The following is a description of a gene set: species: Homo sapiens Genes having at least one occurrence of the motif DNNGGRGGGWWNNNN in the regions spanning 4 kb centered on their transcription starting sites. This matches the SPZ1 transcription factor binding site V$SPZ1_01 (v7.4 TRANSFAC). Human Gene Set: SPZ1_01, and this is the list of marker genes: EIF4G2, ABHD8, CRMP1, BCL7A, EIF4G1, PITPNC1, YTHDF2, LCOR, KCNC1, EIF4E, TOM1L2 (NCBI Gene Id 246315), CTCF, HR, TRMT2A, RIMS1, ADAMTS9, USPL1, TIAM1, MRPL40, CPNE1, GTF2A1, STK35, EPN3, PTMS, DLG2, POU3F3, GPBP1, CHD4, SRCIN1, CAMTA2, WDTC1, FOS, PCSK2, HOXB8, ILF3, HMGA1, SLC44A4, PHF12, CASKIN2, MRC2, AHCYL2, STK4, PPP1R10, EPHB1, PABPC1, DRC3 (NCBI Gene Id 83450), MIR17HG, SYNCRIP, MBD6, SIGIRR, GNAI2, PSD, TPT1, ZBTB3, SZRD1, NFKB2, IGF2BP3, PICALM, NCDN, ECEL1, PTCHD1, PPP2R5C, CGGBP1, RANBP1, DPYSL2, HOXB9, FBRS, TMEM126B, SLITRK1, DDX17, TBCC, VPS26B, GRK5, CYTH3, TBC1D13, MAGED2, ASIC1, NECAB3, FOXJ2, PPP1R1B, NAB2, CLC, CNTFR, EFEMP2, NR2F2, HMGN2, HIVEP1, PAX8, SEC24B, KCNB2, UQCRH, TMTC2, KPNB1, ADRB1, HIF3A (hypoxia inducible factor 3 subunit alpha), LDB1, SOX15, XPO7 (exportin 7), SMARCC1, SPRY4, SKIDA1, BMAL1, HYAL2, MAZ, FST, SP7, ZFP91, ZMYM2, DCTN1, VCAM1, ZNF513, CXXC4, ZNF800, MRPS18B, DQX1 (NCBI Gene Id 165545), ORAI1, ADNP, HTN1, STAC2, SCRT2 (NCBI Gene Id 85508), ZRANB1, UBAP1, FGF13, HOXA10, LMO4, GPM6B, PAX2, IL17B, SLC25A23, SLC17A7, FGF17, KCNN2, MMP1, BLOC1S3, ZNF362, GDF7, HOXC10, CCND2, TRAPPC6A, MEIS2, BCL11A, RBMS3, SP1, XPO1, NYAP1, HIRA, MOV10, RBM12, CALCOCO1, CYLD, FHL3, EPS15, IGF2BP1, SOX3, TPM3, PCF11, DEPDC4, ADAMTSL1, KCNK4, HOXD9, CDK6, PRKCG, CALM2, HOXB1, PRKAG1, UBE2B, HOXA9, OSBPL7, S100A4 (NCBI Gene Id 6275), MYLK, PGR, CNOT4, KCNV2, PRRX1, SP4, BAZ2A, IRX5, SIX4, NLK, NSD3, FAM216B, ZMYND8, HNF1B, MYO1C, AMIGO2, SNRPD1, NCAPD3, STAG2, TNS2, CADM2, ATF3, KCNK2 (potassium two pore domain channel subfamily K member 2), ILF3-DT, HDAC8, ACVR2A, PABPC3, GREM1, CUL2, APH1A, HOXB6, SSBP2, BDNF, RLIM, CDK5R2, FXYD4, TSEN54, MAP1A, DSG4, SHANK1, RASGEF1A, HNRNPLL, GLRA1, WNT10A, SUMO2, POU2F1, FOXO4, GATA3, LRRC41, EBF1, UTP18, MACO1, HAUS3, PATL1, SHH, AKT2, HSD3B7, PIK3C2B (NCBI Gene Id 5287), SOX10, MCUB, DLGAP4 (DLG associated protein 4), HOXB4, SRRM1, NTRK3, F13A1, NPPA